Given this list of marker genes POLR3H, LMNA, NUP107, AARS2, CHP1, FIGLA, GALK1, FSHR, CEP290, NOBOX, FMR1, BNC1, NBN, POLG2, XRCC2, SDCCAG8, C14orf39, SPIDR, POLG, AGK, TTI2, EIF2B1, RIN2, PSMC3IP, CASP10, EIF2B2, POF1B, ZSWIM7, GALT, FAS, HSF2BP, INVS, KASH5, DIAPH2, MCM3AP, LARS2, AIRE, SPATA22, ANAPC1 (anaphase promoting complex subunit 1), GGPS1, PMM2, NPHP4, ANAPC7, FOXL2, WDR19, NPHP1, MSH4, BMP15, CEP164, MRPS22, RCBTB1, DCAF17, B4GALNT1, ERAL1, FASLG, TRAF3IP1, NPHP3, TWNK, ERCC4, MCM8 (minichromosome maintenance 8 homologous recombination repair factor), HFM1, IQCB1, BLM, STAG3, NR5A1, THOC6, here is a description of the gene set: species: Homo sapiens Premature ovarian insufficiency Human Gene Set: HP_PREMATURE_OVARIAN_INSUFFICIENCY Amenorrhea due to loss of ovarian function before the age of 40. Primary ovarian insuficiency (POI) is a state of female hypergonadotropic hypogonadism. It can manifest as primary amenorrhea with onset before menarche or secondary amenorrhea.